Given this list of marker genes Dlg4 (NCBI Gene Id 13385), Wnt2, Wnt6, Wnt5a, Wnt5b, Tmed2, Lrp6, Ror2, Sfrp1 (secreted frizzled-related protein 1), Wnt16, Cthrc1, Wnt8a, Ccdc88c (coiled-coil domain containing 88C), Ryk, App, Dvl2, Znrf3, Gopc, Wnt11, Wnt7a, Rspo3, Wnt9b, Sdcbp, Wnt3, Wnt2b, Dvl1, Magi3, Ndp (NCBI Gene Id 236713), Fzd1, Wnt3a, Dvl3, Wnt10b, Wnt10a, Wnt7b, Wnt9a, Bambi, Myoc, Wnt8b, Rnf43, Wnt4, Wnt1, Fzd7, here is a description of the gene set: studied in species Mus musculus Mouse Gene Set: GOMF_FRIZZLED_BINDING Binding to a frizzled (fz) receptor.